The following is a description of a gene set: species: Homo sapiens Pathway Definition from KEGG: Glycogen -- AMY >> (MGAM,GAA,GANC) -> Glc Glycogen degradation (amylase). Pathway ID: N00720. Pathway type: Reference. Pathway class: nt06017 Glycogen metabolism. Human Gene Set: KEGG_MEDICUS_REFERENCE_GLYCOGEN_DEGRADATION_AMYLASE_, and this is the list of marker genes: GANC, GAA, MGAM2, MGAM, AMY2A, AMY1B, AMY1A, AMY1C (amylase alpha 1C), AMY2B